Given this list of marker genes TRIM13, CYBB, MOGAT3 (NCBI Gene Id 346606), OSBP, OSBPL2, OSBP2, MOGAT2, NOX4, OSBPL3, PIK3R1, ADAM10, OSBPL1A, OSBPL7, CAPN2, SYT6, DBI, CYBA, DGAT2, OSBPL6, CLU, BCAP31, FYN, CISD2, here is a description of the gene set: The portion of endoplasmic reticulum, the intracellular network of tubules and cisternae, that occurs near the nucleus. The lumen of the perinuclear endoplasmic reticulum is contiguous with the nuclear envelope lumen (also called perinuclear space), the region between the inner and outer nuclear membranes. Human Gene Set: GOCC_PERINUCLEAR_ENDOPLASMIC_RETICULUM species: Homo sapiens